Given this list of marker genes Tdg, here is a description of the gene set: electronically inferred by orthology from the curated human pathway This event has been computationally inferred from an event that has been demonstrated in another species.<p>The inference is based on the homology mapping from PANTHER. Briefly, reactions for which all involved PhysicalEntities (in input, output and catalyst) have a mapped orthologue/paralogue (for complexes at least 75% of components must have a mapping) are inferred to the other species. part of: Epigenetic regulation of gene expression Reactome Pathway: TET1,2,3 and TDG demethylate DNA species: Mus musculus